Given this list of marker genes SMAD2, SMAD4, SMAD3, here is a description of the gene set: species: Homo sapiens Reactome Pathway: SMAD2/3 MH2 Domain Mutants in Cancer part of: Loss of Function of SMAD2/3 in Cancer Mutations in the MH2 domain of SMAD2 and SMAD3 affect their ability to form heterotrimers with SMAD4, thereby impairing TGF-beta signaling.<br><br>The SMAD2 and SMAD3 MH2 domain residues most frequently targeted by missense mutations are those that are homologous to SMAD4 MH2 domain residues shown to be involved in the formation of SMAD heterotrimers. Asp300 of SMAD2 and Asp258 of SMAD3 correspond to the frequently mutated Asp351 of SMAD4. Pro305 of SMAD2 corresponds to the frequently mutated Pro356 of SMAD4, while Ala354 of SMAD2 corresponds to Ala406 of SMAD4. Arg268 of SMAD3 corresponds to the frequently mutated Arg361 of SMAD4. SMAD2 and SMAD3 MH2 domain mutations have been examined in most detail in colorectal cancer.